Given this list of marker genes Prkaa2, Ythdf3, Dazap2, Prrc2c, C9orf72, Atxn2l, Prkaa1, Dync1h1, Rps23 (NCBI Gene Id 66475), Ddx3x, Grb7, Becn1, Lsm14a, Ogfod1, Usp10, Fmr1, Atxn2, G3bp2, Styxl1, Caprin1, Ythdf1, Bicd1, Hif1a, Csde1, G3bp1, Tia1, Atg5, Cirbp (NCBI Gene Id 97676), Ddx6, Pum2, D1Pas1, Ubap2l, Ythdf2, Pqbp1, Eif2s1, Ang, Hsf1, here is a description of the gene set: Mouse Gene Set: GOBP_STRESS_GRANULE_ASSEMBLY studied in species Mus musculus The aggregation, arrangement and bonding together of proteins and RNA molecules to form a stress granule.